Given this list of marker genes Fbxw7 (NCBI Gene Id 68467), Ube2srt, Ube2k, Prkn, Elp6, Ube2s (NCBI Gene Id 77891), Plaa, Ide, Vps54, Trim6, Ube2c, Rnf135 (ring finger protein 135), Trim32 (NCBI Gene Id 69807), Ambra1, here is a description of the gene set: studied in species Mus musculus Mouse Gene Set: GOBP_UBIQUITIN_RECYCLING Any process involved in the maintenance of an internal steady state of ubiquitin monomers and free ubiquitin chains at the level of the cell by recycling ubiquitin from proteasome-bound ubiquitinated intermediates.